Given this list of marker genes TUBA8, EIF4G3, PPP2R1B, KPNA3, EIF4A2 (NCBI Gene Id 63124), NUP210, DUS2, TUBA1C, MAPK3, ADAR, NUP35, EIF2S2, HERC5, NUP93, ARIH1, RNASEL, FANCB, TUBA4A, EIF2AK2, HSPA1B, NUP58, NUP50, TUBB8B, ISG15, TUBB6, OAS3, KPNA4, FANCE, NUP214, RANBP2, NUP155, TUBB4A, UBE2N, NUP160, NUP205, AAAS, STAT1, TARBP2, FLNB, DHX9, OAS1, TUBAL3, PPP2R5A, MAVS, UBE2L6, KPNA1, UBE2E1, NUP62 (nucleoporin 62), EIF4G1, TUBA1A, FANCG, NDC1, MAPT, EIF4G2, TUBA3D, SUMO1, NPM1, POM121C, HSPA2, UBA52, EIF4E2, MX1, PTPN2, NUP188, FAAP100, TUBB2A (tubulin beta 2A class IIa), RAE1, TRIM25, NUP43, KPNA7, TUBB8, NUP107, TP53, OAS2, MAP2K6, FLNA, NEDD4, HSPA1L, JAK1, FANCF, PLCG1, NUP88, EIF4E3, RIGI, EIF4E, NUP133 (NCBI Gene Id 55746), PPP2CA, FAAP20, NUP42, CDK1, NUP98, NUP85, RPS27A, CHUK, TUBB3, PIN1, USP18, TPR, TUBB4B, MX2, PPP2CB, IFIT1, ILF3 (NCBI Gene Id 54783), CENPX, EIF2S1, SEH1L, SPHK1, NUP54, IRF3, CENPS, PDE12, NCK1, FANCM, IKBKB, FANCC, HSPA8, FAAP24, FANCA, KPNA2, EIF4A3, PPP2R1A, EIF4A1, PRKRA, NUP153, PPM1B, EIF2S3, TUBB1, UBC, IKBKG, UBB (NCBI Gene Id 91253), STAT3, KPNB1, SEC13, POM121, TUBB2B, TUBA1B, SNCA, ABCE1, UBE2I, DNAJC3, BECN1, TUBA4B, UBA7, HSPA1A, NUP37, FANCL, TUBA3E, OASL, KPNA5, TUBA3C, ILF2, here is a description of the gene set: studied in species Homo sapiens Human Gene Set: REACTOME_ANTIVIRAL_MECHANISM_BY_IFN_STIMULATED_GENES Antiviral mechanism by IFN-stimulated genes